The following is a description of a gene set: studied in species Homo sapiens Human Gene Set: GSE33425_CD8_ALPHAALPHA_VS_ALPHABETA_CD161_HIGH_TCELL_UP Genes up-regulated in KLRB1 high T cells: CD8A versus CD8A CD8B. from publication Walker LJ, Kang YH, Smith MO, Tharmalingham H, Ramamurthy N, Fleming VM, Sahgal N, Leslie A, Oo Y, Geremia A, Scriba TJ, Hanekom WA, Lauer GM, Lantz O, Adams DH, Powrie F, Barnes E, Klenerman P (PMID 22086415) This SuperSeries is composed of the SubSeries listed below., and this is the list of marker genes: BIN1, SPIB, MTCP1, FCGR2B, PKIG, NFE2L1, IGLC7, RNGTT, PLCG2 (NCBI Gene Id 5336), TBC1D14, HLA-DOB, SNX5, HLA-DMB, HLA-DMA, SLC44A2, RUFY1, GGA2, MCL1, PITPNA, MS4A1, RAB14, HEXA, RHOQ (ras homolog family member Q), CCL22 (NCBI Gene Id 6367), RBM4B (RNA binding motif protein 4B), NAGLU, TOR1B, SORL1, IDUA, FUT4, B4GALT3, NFYC, MRPS18A, CD79B, CHUK, SERINC3, CD74, RTTN, ANAPC15, TMEM62, ZNF385A, ADCK1, MIF4GD, CASP4, TM2D3 (TM2 domain containing 3), CD22, ADCYAP1R1, ANKS3, CFL2, SETDB1, SLC30A9, IRF5, ELL2, STARD3, SAFB, CBFA2T2, WFS1, EIF4EBP2, LDB2, CD19, SNX2, SYK, GSTM3, IRF8, PER1, LYN, FCRLA, UPP1, PMPCA, EIF2AK4, HIP1R (huntingtin interacting protein 1 related), CRLF3, STRBP, RYR1, NR1H2, CNN3, SLC30A5, RALB, ITSN1 (intersectin 1), ZNF143, CNR2, KTN1, ERO1B, CTSH, POU2AF1, NDEL1, UBL3 (ubiquitin like 3), ZNF398, BMP2K (NCBI Gene Id 55589), NUCB2, CD79A, MYADM, TCF4, NRAP, BLNK, CTSS, HLA-DOA, EIF4A2, SMIM14, RFLNB, PRKCD, SNX9, BCL2L2, AOPEP, TPD52, LY86, OR10J5, POU2F1, LYL1, UIMC1 (ubiquitin interaction motif containing 1), FICD, SYT2, TEC, NCF4, PCK2, ABCA1, MEF2C, PISD, ARFGAP2, IQGAP1, SELL, FEM1A, SH2B3, IFI30, CD2AP, SPI1 (Spi-1 proto-oncogene), LIMD1, IL4R, RALGPS2, CD72, IVD, HBB, HBA2, C9orf85, HIVEP2, CD40, PCID2 (PCI domain containing 2), MGAT1, EYA1, IMMT, PI4KA, PKIB, TK2, CLK2, CASQ1, EPS15, PLK3, SMARCD2, TRIM11, PHTF2, DCX, MAPK12, TSPAN32, CCR6, SLC16A7, C1R, DYRK1A, IGHM, SRPK3, CBFA2T3, NEURL4, GSN, ZFP36L1, HCK, GAD1, ASH1L, MKNK1, SIPA1, FUT1 (NCBI Gene Id 2523), KANSL2, IL4I1, BTK, NAA80, CRB3, NCF2, HLA-DQA1, WBP2, INPP1, TBK1, CIITA, TXNDC16, APOE, PRKCB, CD81, EIF4G2, NAPSA, GNS, ASNSD1, KCTD12, ANKRD11, BCL6, RFC1, SLC4A7, ZFX, PPIF, HS3ST3A1, IREB2 (NCBI Gene Id 3658), NCAM1, OAT, LPGAT1